Given this list of marker genes Fgf8, Fgf9, Fgf17, Fgfr3, Fgf20, Fgf1, Fgf18, here is a description of the gene set: species: Mus musculus Mouse Gene Set: REACTOME_FGFR3B_LIGAND_BINDING_AND_ACTIVATION FGFR3b ligand binding and activation